The following is a description of a gene set: Mouse Gene Set: GOBP_RETROGRADE_NEURONAL_DENSE_CORE_VESICLE_TRANSPORT species: Mus musculus The directed movement of neuronal dense core vesicles along axonal microtubules towards the cell body., and this is the list of marker genes: Mecp2, Kif5b, Kif1b, Kif1c, Kif5a, Kif1a